Given this list of marker genes NPAS4, TNRC6B, HNRNPA2B1, NCDN, HOXB6, DNAJC5, here is a description of the gene set: species: Homo sapiens Human Gene Set: AGTGCGT_MIR521 Genes having at least one occurence of the motif AGTGCGT in their 3' untranslated region. The motif represents putative target (that is, seed match) of human mature miRNA hsa-miR-521 (v7.1 miRBase).